Given this list of marker genes CREB1, CAND1, TP53 (NCBI Gene Id 7157), WNT10B, PSMC6, here is a description of the gene set: species: Homo sapiens Human Gene Set: GOBP_POSITIVE_REGULATION_OF_RNA_POLYMERASE_II_TRANSCRIPTION_PREINITIATION_COMPLEX_ASSEMBLY Any process that activates or increases the frequency, rate or extent of RNA polymerase II transcriptional preinitiation complex assembly.